The following is a description of a gene set: studied in species Homo sapiens Comparisons of global gene-expression profiles revealed a greater distinction between CD4+ Treg cells and CD4+ conventional (Tconv) T cells residing in abdominal (epidydimal) fat versus in more standard locations such as the spleen, thymus and LN. Human Gene Set: GSE7852_TREG_VS_TCONV_DN from publication Feuerer M, Herrero L, Cipolletta D, Naaz A, Wong J, Nayer A, Lee J, Goldfine AB, Benoist C, Shoelson S, Mathis D (PMID 19633656) Genes down-regulated in comparison of regulatory T cells versus conventional T cells., and this is the list of marker genes: SNHG8, PXYLP1 (2-phosphoxylose phosphatase 1), SPEN-AS1, LBR, MAP4K4, PDE3B, TENT4B, AP3D1, IL17RA, NTRK3, KCTD2, FNBP4, TNFRSF1A, KLF13, DNAJC6, SOX2-OT, ST3GAL6, PIK3R5, ALS2CL, APPL2, RNF146, F8A1, ARID5A, ARL4C, CCDC71L, PRKCQ, PDE4B, TSPAN14, MCTP2 (NCBI Gene Id 55784), CNGA1, ATP8B4, TGFBR2, UGCG, METTL27, PRPF38B, CTDSP2, CDPF1, CDH1, TMEM186, KBTBD2 (NCBI Gene Id 25948), RTN4RL1, TGFBR3, LYPD6B, PTPN11, AMZ1, ICAM2, GPBP1L1, TANC1, MAD2L1BP, PAG1, MAP3K1, MBOAT1, B3GALT4, METTL9, PAQR7, RFLNB, IL1RL2, S1PR1, GABRG2, MBOAT4, PARP16, RNF19A, SLC9A9 (NCBI Gene Id 339579), DSE, LAIR1, SGK1, ITK, RANBP10, LIMK2, GRIPAP1, EMB, GGT1, DENND3, IDO1, FBXL14, GPSM3, EPB41, GRAP2, PPP1R17, ARFIP1, ENTPD5, PCYT2, ATP2A3, USP12, CLN3, OTUD1, NPC2, KLRD1, ZNF652, CD4, CCDC141, TMEM9B, ARHGAP29, INPP5B, KLHL4, CBX4, TMEM161A, MSRA, C19orf38, ADH1C, CCSAP, SMIM6, VIPR1, SEMA4F, MOB3B, PDLIM4, EEIG1 (NCBI Gene Id 90676), SMAP2 (NCBI Gene Id 64744), NFE2L2, LAT, EIF2AK3, PPP6R3, PCCB, SLC30A4, ANKRD13D, RAPGEF4, RNF32, ITGB5, PLEKHA2, THEMIS, TDRP, PEX5, ELOVL7, CYRIA, GRK6, ITGB3, HSD11B1, SLC49A4, ATP6V0A2, AAK1, ENC1, STK26, ZFPM2, INPP1, GPR171, AQP11, GIMAP6, IL21, FHIP2A, TLE4 (TLE family member 4, transcriptional corepressor), IKZF1, PPM1H, RINL, HS3ST3B1, SEMA4A (NCBI Gene Id 64218), COX10, GUCD1, SETDB2, DYRK2, TSPYL4, GRAMD2B, EVI2A, LYST, ITPR1, ABHD15, AP2A2, ORAI2, ALKBH4, SLC20A1, SCML4, IFITM10, ARHGAP45, RMND5B, LONP2, GALNT10, CCDC115, EVI2B, LPAR6, CD28 (NCBI Gene Id 940), ZAP70, CLIP1, SOSTDC1, AP4M1 (adaptor related protein complex 4 subunit mu 1), LANCL3, CHD7, ZFPM1, SHLD1, HIPK1, TTLL12, FAM120AOS, PKNOX1, RCBTB2 (NCBI Gene Id 1102), PLEKHO1, SLC12A7, PIM2, DOLK, DUSP6, EHD3 (NCBI Gene Id 30845), MYH4, GTF2I, LRRC75B, NXF1, EDEM3, SIAH1, DAP, S1PR4 (sphingosine-1-phosphate receptor 4), HPCAL1, FAAH, PGAP1, GIMAP4 (GTPase, IMAP family member 4)